The following is a description of a gene set: studied in species Homo sapiens A form of hepatic steatosis characterized by the presence of large, lipid-laden vesicles in the affected hepatocytes. Macrovesicular hepatic steatosis Human Gene Set: HP_MACROVESICULAR_HEPATIC_STEATOSIS, and this is the list of marker genes: RRM2B, NDUFAF1, POLG, DOCK2, VPS33A, MPV17, SLC25A13, EARS2, CPT2, TYMP, MTX2, LIG3, MICOS13, NAA10, TRMU, LYRM4, CYP7A1